Given this list of marker genes DCHS1, DZIP1, GUCY2D, RP1L1, TENM4, here is a description of the gene set: Typified by age-related disease onset species: Homo sapiens Human Gene Set: HP_TYPIFIED_BY_AGE_RELATED_DISEASE_ONSET Description of conditions in which age of onset is typically later in life and in which penetrance is dependent on the age of the subject.